The following is a description of a gene set: studied in species Mus musculus The chemical reactions and pathways leading to the breakdown of tetrapyrroles, natural pigments containing four pyrrole rings joined by one-carbon units linking position 2 of one pyrrole ring to position 5 of the next. Mouse Gene Set: GOBP_TETRAPYRROLE_CATABOLIC_PROCESS, and this is the list of marker genes: Hmox2, Hmox1, Blvra, Blvrb, Cubn, Slco1b2, Ugt1a1, Urod